The following is a description of a gene set: Any process that modulates the frequency, rate or extent of an antifungal innate immune response. studied in species Mus musculus Mouse Gene Set: GOBP_REGULATION_OF_ANTIFUNGAL_INNATE_IMMUNE_RESPONSE, and this is the list of marker genes: Trim62, Fam3a, Pla2g5 (NCBI Gene Id 18784), Spi1, Usp15 (ubiquitin specific peptidase 15)